Given this list of marker genes PDGFRB, LEF1, MIR15A, GGNBP2, CXCL12, TNN, FOXO4, SHC1, ATP5IF1, PIK3R6, SLC31A1, RORA, ADAM15, ROCK2, MIR495, PKD2, ISM1, CNMD, HAND2, C1GALT1, GAB1, THBS2, MIR10B, NOTCH2, ITGAV, NAGLU, MIR181B1, EMC10, IL10, PTK7, MIR138-1, TMEM100, WDR83, SCN11A, TGFBR1, GATA4 (GATA binding protein 4), ACKR3, RELA, SPINK5, RNH1, PLK2, NOX1, PIK3CG, TGFA, GPLD1, FOXC2, COL1A1, MIR16-1, LLGL2, NRCAM (neuronal cell adhesion molecule), FZD4, EFEMP2, TMIGD2, SIX1 (NCBI Gene Id 6495), DCN, SYK, EGR3, MDM2, MIR149, JMJD8, PDGFRA, CDX2, EREG, PROK1, YAP1, NOTCH3, GHSR, MIR200B, PTPRB, FAM3D, TAL1, SPRY2, TGFBI, ITGB3, RRAS, TGFBR3, MIR18A, GRN, ECSCR, SLIT2 (slit guidance ligand 2), WNT2, ROCK1, MIR22, E2F2, FGF6, MIR296, MIR153-1, MAP2K5, RAMP2, ANPEP, ANP32B, OPTC, KLF5, PDGFA, CCN2, PTPRM, LOXL2, NODAL, FGFBP1, CLEC14A, ARHGAP22, PDPK1 (3-phosphoinositide dependent protein kinase 1), RNF213, CFLAR, HYAL1, WARS2, CELA1, MIR200C, VAV2, COL18A1, JAM3, ROBO1, PRDM1, PTK2, XBP1, NTRK1, GPC3, ZNF304, MIR125B1, MIR320A, PTK2B, DSG2, JUNB, ALDH1A2, ATF2, SPHK2, ESM1 (NCBI Gene Id 11082), FOXJ2, TGFBR2, RTN4, GBX2, PRKCB, GJC1, CAMP, ABL1, HHIPL1, FKBP10, ADAMTS9, ABCC9, MIR1908, PROP1, RAPGEF2, MYH9, EPGN, FZD5, EIF2AK3, MIR483, FOXF1, BMPER, MESP1, ITGAX, FBLN5, DDAH1, ACVR1, CLIC4, WNT5A, HEG1, SP100, SOD2, MIR101-1, MIR27A, TFAP2B, CHI3L1, CCN6, CASP8, PAK4, KDR, MIR410, SERPINF1, ROM1, LEP, NF1, COL8A1, ID1, CCDC134, GPER1, LYL1, LEPR, GATA2, IL1A, PKM, NOTCH1, HAS2, CALCA, ADGRF5, LOXL1, ALOX5, PAX6, MIR492 (microRNA 492), GLI3, MEOX2, SMAD6, PLXDC1, SIRT1, GLMN, PDE2A, NFATC1, CTH (NCBI Gene Id 63046), ELK3, MDK, MIR451A, TBX1, RIN2, FZD8, TNF, MIR99B, CYBB, EMILIN2, CEACAM1, PDCD4, ROBO2, KLF4, HDAC7, SRPK2, NRXN1, SEMA5A, MIR205, PDCD10, MIR640, RHOB, KIT, MEIS3, NAXE, RBM15, PF4, CRKL, MIR30A, RIC8A (RIC8 guanine nucleotide exchange factor A), MIR329-1, HSPB6, NPPB, RHOA, HOXB13, MIR143, MIR92A1, FAP, EPHB4, NPPC, HIPK1, NR2F2, PIK3CA, WNT7A, AKT3, PRCP, MIR505, HMGA2, MIR342, TGFB1, GATA6, HHEX, MIR29B1, WNT11, LRP1, PLXND1, FOXC1, ERRFI1, TBX3, CCN3, TNFAIP2, ITGA5, WNT4, SUFU, ABCC8, PDPN, UBP1, MIR27B, MECP2, MIR29A (NCBI Gene Id 407021), SARS1, DLX3, NDNF, TAB1, EGFL7, ZFP36L1, QKI, LOX, ACTG1, MIR20A, EPN1, MIR221, TBX20, MIR150, HOXA1, ISL1, HES1, MIR424, CYP1B1, NRP2, NEDD4, PIK3CB, KLF2, ADIPOR2, PRKD1, HPGD, ZNF354C, NAA15, JMJD6, ZC3H12A, MIR15B, GADD45A, MIR145, ETS1, DLL4, FOXN1, CTNNB1, COL4A2, PIK3C2A, VEGFA, MIR23A, FLT4, VPS4B, ANGPT2 (NCBI Gene Id 285), MIR1-1, MIR17, VAV3, APLNR, SAT1, DCTN5, NR2E1, SEMA4A, KCNJ8, FMNL3, MIR29C, PACSIN2, TSPAN12, ATP5F1B, FGFR2, PDGFB, SOX18, HTN1, ZMIZ1, MIR494, CHRNA7, MICALL1, ACTA2, ERAP1, COL4A1, RUNX1, MIR1298, PITX2, B9D1, SGPL1, ANG, S100A1, ADAM12, LARGE1, MIR378A (NCBI Gene Id 494327), CX3CL1, AGO1, PKD1, EMP2, PKNOX1, ITGB1, MMP19, MIRLET7B (NCBI Gene Id 406884), CD93 (CD93 molecule), SPI1, IL6R, PANK2, MED1, SEMA3E, PPP3CB, ECM1 (NCBI Gene Id 1893), PRICKLE1 (prickle planar cell polarity protein 1), PGK1, COL3A1, MIA3, MYDGF, SPRED1, SRF, EGLN1, MIR20B, LAMA1, MIR130A, THY1, ADTRP, TJP1, MEF2C, JAG1, ANGPTL6, JCAD, STK4, OTULIN, SOX17, KRT1, LUZP1, E2F8, ATP7A, CXCL17, B4GALT1, TNNI3, NSDHL, ANGPT1, GNA13, PGF, OVOL2, TNFSF12, BMP7, STIM1, HEY2, FBXW8, PRKD2, HOXA7, MIR361, ACVR2B (activin A receptor type 2B), NRXN3, CITED1, CIB1 (calcium and integrin binding 1), MIR222, RECK (NCBI Gene Id 8434), SOS1, IL1B, VASH1, PAXIP1, PPARG, MIR34C, SIRT6, NRP1, AGO2, JUN (Jun proto-oncogene, AP-1 transcription factor subunit), LIF, MIR26A1, MIR1224, PRKCA, CDH13, LRG1, FYN, NOS3, SNX17, DAB2IP, SOCS3, MIR21, PIK3R3, ARHGEF15, GHRL, MIR487B, NOTCH4, FBXW7, TLR3, TNFRSF12A, TEK, ADAM8, TMEM204, RGCC, NUS1, CFC1B, FOXS1, MAPK1, MYO1E, PECAM1, CD160, ENG, EPHA1, BAX, CTNND1, NDST1, HDAC9, S1PR1, F3, CCM2 (NCBI Gene Id 9225), COL8A2, FGF8, CLDN5, LRP2 (NCBI Gene Id 4036), PRRX1, CFC1, DYNC2H1, CHD7, PLCG1, MIR193A, AAMP, EMILIN1, APLN, ANGPT4, TCF21, MIR146A, MIR106B, PDGFD, CXCR3, SPARC, C3, TMEM201, NINJ1, COMT, RASIP1, HEY1, BMP2, MIR140, MYLK, AMOT, S100A7, PTGS2, GJA4, CREB3L1, MIR206, SERPINB7, MTDH, RLN2, CEMIP2, RAMP1, CRIPTO3, MIRLET7A1, APOE, PRL, HMOX1, MAPK14, HECTD1, HLA-G, IL17F, CALCRL, ITGA2B, MIR100, PTPRJ, ADAMTS1, HMGB1, ZBTB14 (NCBI Gene Id 7541), IL18, GTF2I, THBS1, BCAM, PTGIS, MINAR1, MIB1, SYNJ2BP, MIR214, NFATC4, RASA1, TNFAIP3, APOH, HIPK2, HGS, ITGB8, GREM1, CCBE1, NFATC3, EPHB3, BTG1, POFUT1, VSTM4, FGF9, ENPEP, ADAM10, KLK3, CITED2, YJEFN3, EFNA3, TBX5, EFNB2, ASB4, MIR10A (NCBI Gene Id 406902), MIR196A1, NKX3-1, ADGRB2, COL1A2, HTATIP2, SMOC2, AMOTL1, FN1, ANXA1, SOX4, STK11, BSG, HSPB1, AP2B1, TBXA2R, SERPINE1, MIR9-1 (NCBI Gene Id 407046), WARS1, IL12A, ADAMTS6, SULF1, BMPR1A, SEC24B, PTPN20, FGFR1, OR10J5, PXDN, EHD4, MEIS3P1, ADGRA2, MIR34B, PIK3CD, SHH, MIR30C1, HOXA5, MIR377, FASLG, PSEN1, MYOCD, CCR3, UNC5B, STAT1 (signal transducer and activator of transcription 1), HRG, SGCB, SASH1 (NCBI Gene Id 387570), SHB, ANGPTL7, TMED2, EFNA1, OSR1, PDCD6, TCF7L2, MIR885, C3AR1, EDN1, EGF, ZFPM2, VEGFB, SLC12A2, VEGFC (vascular endothelial growth factor C), NPR1, ARHGAP24, CD47, HIF3A, TIPARP, HOXA13, VASH2, MIR24-1, SRPX2, ERBB2, WNK1, ADM, MEIS1, EDNRA, PPP3R1, DAG1, NPR2, BMP4, NPRL3, MIR132, IHH, CCL24, FLT1 (fms related receptor tyrosine kinase 1), CD36, E2F7, FGF2, NDP, BAK1, PLPP3, MAP2K1, MIR939, STARD13, FGF16, PDCL3, MIR503, MAPK7, ANXA3, ADM2 (adrenomedullin 2), MFGE8, AIMP1, NOG, DDIT3, JAK1, STAB1, SLC2A10, MIR210, GPX1, BCAS3, EPAS1, MMP14, TBX2, WNT7B, SMAD1, SPINT1, JUP, CCR2, FKBPL, MIR217, CXCR4, GDF2, VEZF1, LRP5 (NCBI Gene Id 8058), TBX4, MIR497, SGCD, HOXB3, RSPO3, EPN2, FOXO1, SLC12A6, NTRK2, MIR125A, HK2, STRA6, SFRP2, NCL, TEAD2, IGFBP7, TIE1, CXCL10, PARVA, MCAM, FGF10, THBS4, LIPA, CAV1, STAB2 (stabilin 2), MYO18B, MEGF8, AMOTL2, CX3CR1, HS6ST1 (heparan sulfate 6-O-sulfotransferase 1), CCN1, GPR15, ATP2B4, MIR19B1, MIR30E, RBPJ, HAND1, SMAD7, MIR223, IMMP2L, ANGPTL4, FLVCR1, HOXA3, MAP3K3, CDX4, TSPAN18, C5AR1, SP1, MIR31 (microRNA 31), STAT3, RAPGEF3, ARID2, TYMP, TERT (telomerase reverse transcriptase), VEGFD, EYA1, CD34, AKT1, TNMD, PPP1R16B, MIR30B (NCBI Gene Id 407030), TAFA5, CMA1, PTPN6 (NCBI Gene Id 5777), ANTXR1, AQP1, KRIT1, BMPR2, TGM2, MMRN1, MIR199A1 (NCBI Gene Id 406976), AHR, CNTRL (NCBI Gene Id 11064), WASF2, PML, ADGRB1, SMO, MINAR2, EDN2, EPHA2, APOD, ITGB1BP1, SEMA3C, FGF1, NPR3, NFATC2, CD40, ANGPTL3, MIR199B, MMRN2 (multimerin 2), HSPA12B, MIR19A, COL5A1, GPR4, CDH5, EGFL8, MIR137, ADGRG1, PLCD3, RHOJ, SLC1A1, YWHAZ, BRCA1, MIR375, LDLR, CSPG4, NRARP, GLUL, DLL1, PDE3B, CDH2, APELA, CXCL8, HDAC5, PCDHA10, FUT1, ZFAND5, CUL7, PLG, MIR126, MYH10, MMP21, CCL2, SEMA6A, APOLD1 (apolipoprotein L domain containing 1), EGR1, MIR2355, TWIST1, NR4A1, HSPG2, CRIPTO, NOX5, MIR212, MMP2, SH2D2A, FGF18 (NCBI Gene Id 8817), CCL11, CARD10, NGFR, COL4A3, AGTR1, WT1, MIR185, IGF1, MIRLET7F1, EPHB2, HIF1AN, RAP1A, IL6 (interleukin 6), FOSL1, APOB, CLIC3, GJA5, IL12B, SVEP1, PROK2, EGR2, AGGF1, NKX2-5 (NCBI Gene Id 1482), FOXH1, HIF1A, GAA, HPSE, ITGB2, THSD7A, ETV2, LGALS8, TMEM231, ACVRL1, MIR34A, ANXA2, FOLR1, DNMT1, TGFB2, PTPN14, COL15A1, SFRP1, COMP, ADGRG6, NFE2L2, ADGRB3, EPHB1, PROX1, SPHK1, CXCL13, TMEM215, PRKX, SERPINF2, ROBO4, SCG2, TREX1 (three prime repair exonuclease 1), MIRLET7G, GPNMB, here is a description of the gene set: Human Gene Set: GOBP_VASCULATURE_DEVELOPMENT studied in species Homo sapiens The process whose specific outcome is the progression of the vasculature over time, from its formation to the mature structure. The vasculature is an interconnected tubular multi-tissue structure that contains fluid that is actively transported around the organism.